Given this list of marker genes SESN2, MTX2, CENPH, CEP83, SHROOM1, PSRC1, EEF2, PLK2, ATPAF2, SCTR (secretin receptor), NDC80, CENPM, VDAC2, PALS2, CDC6, GZMH, ARHGAP33, LAG3, MYH7, TFPI2, SPINK8, IFIH1, ROPN1L, CCT4, REEP5, LRRC40, SPC24, NUBP1, GLRX3, SHISA9, ALMS1, SLC9B2, DCXR, DLGAP5, E2F7, RAD51AP1, FARS2, YBX1, RND2, PTRH1, POLR3C, INTS12, ENY2, CKAP2L, SLC35D1, HSPA1B, CENPT, ATP5MF, ATP5PO, CCL1, WDR91, CPNE2, SHTN1, EHD1, MRPL19, PLP2, NCAPG2, SLC25A3, MTFR2, ITPRID2, TFRC, PRADC1 (protease associated domain containing 1), CRYZ, HAUS1, SNRNP27, IRF9, IQGAP3, ERCC6L, TUBGCP2, CALU, NKIRAS2, DYNLRB1, APRT, ECI2, KIF18A, NME1, EPRS1, ATP5IF1, CTSB, MVD, ZNF771, MVK, SCG2, RNASEH2B, TEDC1, STK35, IFITM3, ZBTB32, HINT1, VWCE, SCN1B, PEG10, OXA1L, MPZL2, KIF11, RHBDF2, CKS1B, SUPT3H, CCNE1, TIPIN (NCBI Gene Id 54962), ASNSD1, DEPDC1, NPY (neuropeptide Y), COMMD10, COPS2, VCL, FSCN1, MMS19, CKS2, PRR11, PKMYT1, GAS2, SRP72, MPG, SLC35F5, CACFD1, SCN4B, CACNG2, PITPNM2 (NCBI Gene Id 57605), CCP110, SLC12A4 (NCBI Gene Id 6560), MCM5, IFT25, NINJ2, NRM, GLB1, MISP, CCT2, NENF, RAN, PHACTR2, THYN1, TICRR, CCDC34, SPAG5, PTTG1, ATP5MC2, RAD51B, NDUFB5, MCM7, CDKN2C, RBMX2, NTF3, PTMS, PFDN1, ESCO2, KCNK4, SLC9A5, EXTL2, CUX1, SMC4, OPTN, SCIN, RAD54L, CRELD1, NELFE, FAM177A1, CENPN, MED11, GINS1, KNSTRN, PIN4, SLIRP, TICAM1, LGALS1, PIERCE1, CEP128, BCAT1, DSTN, ICAM4, DCAF4, EHD4, PLA2G12A, NDUFB10, MRPL32, IFT22, PLEK, DTL, GGH, TMEM14A, SLIT3 (slit guidance ligand 3), AMOTL1 (NCBI Gene Id 154810), NTF4, EIF2S2, UCHL3, PTP4A3 (protein tyrosine phosphatase 4A3), NAP1L1, WDR62, KIFC1, CENPU, CDCA2, SEC61G (NCBI Gene Id 23480), CENPP, INSL6, CHTF18, RPL3, TIMM17B, PLK4, RFC4, CAV2, here is a description of the gene set: from publication Yu P, Lübben W, Slomka H, Gebler J, Konert M, Cai C, Neubrandt L, Prazeres da Costa O, Paul S, Dehnert S, Döhne K, Thanisch M, Storsberg S, Wiegand L, Kaufmann A, Nain M, Quintanilla-Martinez L, Bettio S, Schnierle B, Kolesnikova L, Becker S, Schnare M, Bauer S (PMID 23142781) Genes up-regulated in splenocytes with viral infection: Baki-1 MuLV versus Sendai. Human Gene Set: GSE24671_BAKIMULC_VS_SENDAI_VIRUS_INFECTED_MOUSE_SPLENOCYTES_UP The genome of vertebrates contains endogenous retroviruses (ERVs) that have resulted from ancestral infections by exogenous retroviruses. ERVs are germline encoded, transmitted in a Mendelian fashion and account for about 8% of the human and 9.9% of the murine genome, respectively1, 2. By spontaneous activation and reintegration ERVs may cause insertional mutagenesis and thus participate in the process of malignant transformation or progression of tumor growth3, 4. However, if the innate immune system is able to recognize and control ERVs has not yet been elucidated. Here we report that, in vitro, nucleic-acid sensing TLRs on dendritic cells are activated by retroviral RNA and DNA from infected cells in vitro. Infection of TLR competent wild type mice with murine leukemia virus (MuLV)-like ERV isolates results in non-canonical gene upregulation, independent of type I IFN. In vivo, TLR3, -7 and -9 triple deficient mice (TLR379-/-) and mice with non functional TLR3, 7 and 9 signaling due to a mutation in UNC93B develop spontaneous ERV-induced viremia. More importantly, in TLR379-/- mice ERV-induced viremia correlates with acute T cell lymphoblastic leukemia (T-ALL). Multiple independent TLR379-/- T cell leukemia lines produce infectious MuLV of endogenous origin. These cell lines display de novo retroviral integration into the Nup214 or Notch1 gene locus leading to gene dysregulation that is reminiscent of aberrant Nup214 and Notch1 expression in human T-ALLs5. Overall, our results demonstrate that in addition to their role in innate immune defense against exogenous pathogens, TLR3,-7, and -9 may be essential for the control of endogenous retroviral mediated T-cell lymphomagenesis. species: Homo sapiens